Given this list of marker genes Ifng, Tnf, Rdh16f2, Rdh19, Rdh9, Clybl, Rdh1, Rdh10, Rdh16, here is a description of the gene set: studied in species Mus musculus Mouse Gene Set: GOBP_POSITIVE_REGULATION_OF_VITAMIN_METABOLIC_PROCESS Any process that activates or increases the frequency, rate or extent of the chemical reactions and pathways involving a vitamin, one of a number of unrelated organic substances that occur in many foods in small amounts and that are necessary in trace amounts for the normal metabolic functioning of the body.